Given this list of marker genes GABBR1, DAPP1, IPP, AGR3, ABHD6, MPDZ, ARF4, IL12RB2, MOB4, MPP1, CYP4A11, TPGS1, HECTD1, LUC7L3, AQP9, BLTP2, CACNA2D3 (calcium voltage-gated channel auxiliary subunit alpha2delta 3), HTRA3, HSD3B2, IMMP2L, PLAAT1, CENPF, ACVR1, CNTN2, CTLA4, LIMK2, KIF3B, HCN1, EFHD2, MFN2, ANTXR2, HDAC2, CPEB2, CENPC, FBXO38, ARHGAP18, BANF1, LAP3, MAN2C1, CRMP1, ANLN, RETREG3, LBR, HSD17B10, B4GALT1, GRAMD2B, AP4M1, CABP5, MGLL, DIP2B, MSRB2, JAK1, ERCC8, MLXIP, CSF2RB, DDX47, EEIG1, CMPK2, HAT1, FAM227B, DSTYK, FLOT2, EMP3, GHITM (NCBI Gene Id 27069), CXorf38, ALS2, FAM20B, F5, AMMECR1L, JAM2 (NCBI Gene Id 58494), ANKRD46, APPL2, TLNRD1, TMEM242, KCNJ15, ISG15, GRSF1, GRB7, KPNA6, GALK2, KDELR1, CDO1, CLUAP1, NAB1, MARK2, IFT88, MCM3, CUL4A, IFT122, DLX3, EYA2, CKMT2, FUCA2, L2HGDH, ELF1, ATP11B, GABPA (GA binding protein transcription factor subunit alpha), CH25H, CNTN6, MRFAP1L1, LAMC2, ATN1, ATL2 (atlastin GTPase 2), CENPB, KIT, BCAP31, COX7A2L, C1orf43, CHRNB2 (cholinergic receptor nicotinic beta 2 subunit), CYP3A43, ASCC2, GOLGA5, MAL, MYO1B (NCBI Gene Id 92451), CORIN, C21orf91, EMC9, SLC25A51, HNRNPK (NCBI Gene Id 3190), ERC1, LY6G6C, LAIR1, ACOT8, ICE2, MCAM, EREG, DPP3, AFM, ILRUN, GPR34, DOK1, DIS3, APLNR, MAX, GNAQ, LAMA2, FANCI, AMHR2, KIF1A, MR1, AIM2, MTF2, CELF2, COX6B2, HES6 (NCBI Gene Id 94875), KIF13A, GNA14, MS4A6A, NAPB, KCNJ2, ABCB7, IFNGR1, ETV3, JPT1, RMC1, GPR50, CENPH, KIF20A, DPYS, DUSP12, ATF5, MRPL42 (mitochondrial ribosomal protein L42), FASTKD5, IFNA1, MCM5, CAMK2G, CEP85, BNIP2, LAMTOR5, FCGR1A, MAGOHB, NSG1, CDK16, DERL1, KRT32, CYSTM1, BOD1L1, VPS50, GML, GHRL, KRT13, DUSP9, EPGN (epithelial mitogen), F13B (NCBI Gene Id 2165), CYP4F3, MTF1, CD248, ARHGAP12, ALDH1B1, GALNT6, BLM, HSPB8, ESAM, COA3, EPHA1, CDC25A, ADD1, SMIM3, BIRC5, MFSD5, here is a description of the gene set: from publication Amit I, Garber M, Chevrier N, Leite AP, Donner Y, Eisenhaure T, Guttman M, Grenier JK, Li W, Zuk O, Schubert LA, Birditt B, Shay T, Goren A, Zhang X, Smith Z, Deering R, McDonald RC, Cabili M, Bernstein BE, Rinn JL, Meissner A, Root DE, Hacohen N, Regev A (PMID 19729616) mouse primary BMDCs were stimulated with tlr ligands and gene expression changes were profiled on Affymetrix arrays studied in species Homo sapiens Human Gene Set: GSE17721_CTRL_VS_LPS_0.5H_BMDC_UP Genes up-regulated in comparison of control dendritic cells (DC) at 0 h versus those stimulated with LPS (TLR4 agonist) at 0.5 h.